Given this list of marker genes KRT14, NEFL, PKP2, BBLN, PKP1, NEFH (NCBI Gene Id 4744), EPPK1, NEFM, here is a description of the gene set: studied in species Homo sapiens Human Gene Set: GOBP_INTERMEDIATE_FILAMENT_BUNDLE_ASSEMBLY The formation of the bundles of intermediate filaments. Intermediate filament-associated proteins (IFAPs) cross-link intermediate filaments with one another, forming a bundle or a network, and with other cell structures, including the plasma membrane. The organization of intermediate filaments and their supportive function in various cells types depends in large part on their linkage to other cell structures via IFAPs.